Given this list of marker genes GNPTAB, RBM8A, COL2A1, SALL4, TRPV4, EIF2AK3, NANS, EXOC6B, ALDH18A1, KIF22, COMP, DYM, RSPRY1, here is a description of the gene set: Underdevelopment of one or more carpal bones. species: Homo sapiens Human Gene Set: HP_CARPAL_BONE_HYPOPLASIA Carpal bone hypoplasia